Given this list of marker genes Slc30a3, Defb34, Ap3b1, Bloc1s6, Snapin, Syt4, Bloc1s5, Ppfia3, Defb37, Defb1, Defb15, here is a description of the gene set: Mouse Gene Set: GOCC_MICROVESICLE species: Mus musculus An extracellular vesicle released from the plasma membrane and ranging in size from about 100 nm to 1000 nm.